Given this list of marker genes FMR1, ADORA1, LILRB2, SHANK3, PENK, IQSEC2, SORCS3, KCNB1, GRID2, STAU2, AGER, ADCY8, CBLN1, ARC, MAPT, here is a description of the gene set: Any process that modulates the frequency, rate or extent of long term synaptic depression. species: Homo sapiens Human Gene Set: GOBP_REGULATION_OF_LONG_TERM_SYNAPTIC_DEPRESSION